Given this list of marker genes RELA, ENC1, ARID5B, CHERP, ZNHIT3, ORC5, GORASP2 (golgi reassembly stacking protein 2), VWA3A, ZNF345, BLMH (bleomycin hydrolase), MYLK, FAM170B, PROX1, SLC23A1, CYP27B1, MSI1, FERRY3, KDM3B, GUCY1A1, PDPR, EIF4B, SLC13A3, SMG7, PCDH9 (protocadherin 9), TPGS2, NDUFB3, PIRT, ABRAXAS2, C2orf68, CKMT2, ABCG4, SMARCD2, POPDC2, NR4A3 (NCBI Gene Id 8013), BLOC1S3, PDS5A, CGN, ZPBP2, DNAJC25, G2E3, FAXC, RGS8, BLOC1S6, ZNF436, TRPM3, MAPK14, BTBD7, here is a description of the gene set: Human Gene Set: MIR5192 from publication Chen Y, Wang X (PMID 31504780) Genes predicted to be targets of miRBase v22 microRNA hsa-miR-5192 in miRDB v6.0 with MirTarget v4 prediction scores > 80 (high confidence targets). species: Homo sapiens